Given this list of marker genes TGFBR3, NRP1, GATA3, APLNR (apelin receptor), MDM2, PARVA, NOTCH1, FZD2, BMP4, HOXA13, TBX2, HEG1, PTK7, SEMA3C, CCN1, LRP2, LUZP1, PLXND1, CRELD1, NKX2-5, MDM4, MKS1, MSX2, HAND1, WNT5A, FGF8, DCTN5, WNT11, STRA6, BMP5, MATR3, NOG, ROBO2, DNAH11, BMPR1A, SNX17, NPRL3, SUFU, NOTCH2, BMPR2, TBX20, FGFRL1, PAX8, TGFBR2, ADAMTS19, PROX1, ROBO1, ID2, KCNJ8, NOS3, ZBTB14, ACVR1, PRDM1, CHD7, ANK2, SMAD6, DAND5, RBPJ, SMAD7, TRIP11, MIR17HG, SMAD4, TBX3, TGFBR1, BMP7 (NCBI Gene Id 655, bone morphogenetic protein 7), SOX11, FRS2, PDE2A, HEYL, RARA, MAML1, HEY2, RBM15, GJA5, SALL1, SLIT3, SLIT2, CITED2, SALL4 (spalt like transcription factor 4), TBX5, CNTRL, TAB1, NPHP3, ADAMTS6 (NCBI Gene Id 345667), SAV1, FZD1, HECTD1, SMO, EGLN1, XIRP2, ENG, NSD2, NDST1, ZFPM2, MYH10, TBX1, GATA6, TGFB2, AP2B1, VANGL2, HES1, RARB, TP53, GATA4, LMO4, ZFPM1, MIR1-1, FGFR2, JAG1, ISL1, HEY1, SOX4, PITX2, NRP2, DHRS3, here is a description of the gene set: species: Homo sapiens Human Gene Set: GOBP_CARDIAC_SEPTUM_DEVELOPMENT The progression of a cardiac septum over time, from its initial formation to the mature structure.